Given this list of marker genes SEPTIN9, ATF3, NRG4, BCL11A, NAPA, RNF44, LCOR, CDC42SE1, CHRM1, JAG2, CNNM4, RANGAP1, CAPRIN2, THRB, GOLGA6L6, RIPOR2, RAB1B, HP1BP3, ORAI2, BATF2, BNIP2, MBD1, MYLK2, LONRF2 (NCBI Gene Id 164832, LON peptidase N-terminal domain and ring finger 2), FCRLA, AFDN, HEPACAM, TSPAN11, DUSP13A, CDIP1, ITPRIP, FYCO1, MEST, MOB1B, CTNNA2, PTPRU, EPHA6, MAPK4, GOLGA4, PPP4C, LYPD3, SNX17, AK1, HS6ST1, LRTOMT, ZBTB20, TRPM1, GPR137C, RAB4B, ZNF540, PSMD11, SNX27, DBN1, TMEM184B, BACH2, LHFPL4 (LHFPL tetraspan subfamily member 4), HCFC2, TAPBP, SLC13A4, NFYA, ILVBL, RBM14, MYO1E, LOXL3, SPEG, AGO1, BPIFA1, IDH3G, TCTA, PPP4R2, FAXC, TP53I11, HPCAL4, DCTD, EBF4, CSTPP1, GYS1, LARGE1, AAK1, EPN2, SUSD6, TMEM101, BGN, SLC39A13, IQSEC3, CD209, ZNF592, CHD8, DAG1, MTCL2, MAGI1, NGFR, NDUFB4, SARM1, SYNGR3, TFCP2L1, TSPAN7, TBX21 (NCBI Gene Id 30009), ELMO2, FBXO41, RHOA, ZDHHC3, EPB41L1, CLDN4, SLC22A13, UBFD1, VAMP3, GAS8 (growth arrest specific 8), MRAP2 (NCBI Gene Id 353265), ADRA1A, FAM78B, ALX4, KHNYN, STUM, SORD (sorbitol dehydrogenase), DENND1A, TIGD5, NOS1, MAP2K3, IMPDH1, ZNF710, GRK2, SEMA5B, NATD1, NOTCH3, RNF216, TCP11X2, RFT1, EDC3, COL26A1, POR, IDS, TAFA4, KCNMA1 (NCBI Gene Id 3778), here is a description of the gene set: Genes predicted to be targets of miRBase v22 microRNA hsa-miR-4640-5p in miRDB v6.0 with MirTarget v4 prediction scores > 80 (high confidence targets). species: Homo sapiens from publication Chen Y, Wang X (PMID 31504780) Human Gene Set: MIR4640_5P